The following is a description of a gene set: from publication Gautam P, Hamashima K, Chen Y, Zeng Y, Makovoz B, Parikh BH, Lee HY, Lau KA, Su X, Wong RCB, Chan WK, Li H, Blenkinsop TA, Loh YH (PMID 34584087) Human Gene Set: GAUTAM_EYE_CHOROID_SCLERA_MONOCYTES species: Homo sapiens Occular cell types curated from Gautam and Hamashima et al. Multi-species single-cell transcriptomic analysis of ocular compartment regulons, and this is the list of marker genes: CIB1, MT-ATP8, CNOT3, AMY2B, RBBP8, AGTRAP, ARL5A, RAE1, STX7, SERTAD2, CD69, PRAM1, MSL2, CRIP1, DOK3, GAS2L3, NUBP1, SHMT1, ADA2, ARHGAP9, BORCS6, RNF135, MAP4K4, PLAGL2, ITGA5 (integrin subunit alpha 5), BRMS1, CLN8, CTSH, CD300C, PFKL, MAPKAPK5-AS1, TAMALIN, EHBP1L1, SPCS3, PDE6H, SFT2D1, PML, PTK2B, KDM2B, SEMA6B, ZNF738, DOCK11, FSCN1, SPOPL, SIPA1, LILRB4, OTULIN, RGS18, CENPL, PREX1, TNFAIP8L1, ACTR2, CASP10, LINC01001, RALGDS, H2BC8, C4orf33, RNF138 (ring finger protein 138), CDC25B, SNX5, DOCK2, RAB5C, UBXN11, NUMB, CNPPD1 (cyclin Pas1/PHO80 domain containing 1), SMCO4, ARHGAP5-AS1, ARHGEF40, H2BC4, SLC30A1, RETN, PSTPIP1, HGS, RAPH1, CYBC1, GPSM3, THAP9-AS1, PURB, MILR1, PIK3CG, CXCL1, HMGA1, HLX, SNX27, LIMS1, IGSF6, BTK, ADAM8, SLC7A7, LINC00528, NECAP2, TRIM14, ARAP2, HECA, UBE2S, EHD1, HIGD2A, GAPT, GLIPR1, BAX, PTPN12, SRGAP2, ARHGAP15, C9orf72, TNFSF13B, SLC1A4, VOPP1, CHD7, GAS6, ARHGAP25, VMA21, PTPN1, ASGR1, IL27RA, NXT1, PLEKHA2, PPP1CA, PICALM (phosphatidylinositol binding clathrin assembly protein), KLHL6, ABHD2, SPATA13, TMEM70, H2BC11, DCP2, ILF3-DT, TIGAR, TMUB1, MSMO1, DGKA, FAM53C, DOK1, DPYD, ASAH1, DPYSL2, LEAP2, PCNA, ADAM9, ARHGAP30, SNAPC1